The following is a description of a gene set: from publication Chen Y, Wang X (PMID 31504780) studied in species Mus musculus Genes predicted to be targets of miRBase v22 microRNA mmu_miR_6540_3p in miRDB v6.0 with MirTarget v4 prediction scores > 80 (high confidence targets). Mouse Gene Set: MIR_6540_3P, and this is the list of marker genes: Appl2, Sema4a, Rab8b, Smarcd1, Slc36a1, Igsf9b, Rnf38, Tex14, Gpr39, Cyth1, Ddc, Tlk2, Adk, Pcnx3, Kcnj11, Etfbkmt, Ptpn11, Klhl4, Pik3r3, Appl1, Gabra2, Naa16, Senp7, Hnrnpr, Gm6377, Usp34 (ubiquitin specific peptidase 34), Ddi2, Clgn, Arhgap21, Obox3, Foxo1, Upf2, Zfp24, Atad2b, Plagl2, Nptn (NCBI Gene Id 20320), Brox, Sdc4, Lmtk2, Efr3a, Alx4, Fmo5, Fcrl1, Mier2, Api5, Prpf8 (NCBI Gene Id 52899), Myh10, Adam22, Hnrnpd, Topbp1, Rbm27, Cct6a, Agpat3, Col19a1 (NCBI Gene Id 12823), Grem1, Pacc1, Kansl1, Usp40, Mybl1, Zfp316, Ankle1, Kcnd2, Abi3bp, Prrc2b, Camsap2, Ark2n, Eif4g3, Ppp6r2, Setd2, Crppa, Ltbp2, Atat1, Kcna2, Tm2d3, Dpt, Timm22, Lpp, Sema5a (NCBI Gene Id 320921), Prox1, Kcnt2, Ttll5, Zfp711, Tbc1d5, Npas3, Pxmp2, Ric3, Gas1, Sdcbp, Wtap, Castor1 (cytosolic arginine sensor for mTORC1 subunit 1), Polr2d, Trem2, Hmgb2, Fn1, Gpcpd1, Prelp, Nipa2 (NCBI Gene Id 93894), Elapor2, Tceanc2, Ank3 (ankyrin 3, epithelial), Sv2c, AI597479, Zfp467, Rgs19, Snrnp40, Rnf169, Nr2e1, Srpk2 (NCBI Gene Id 22382), Dbn1, Fam234b, Trim2, Asb15, Galnt11, Lsm6, Thap11, Hspd1, Dab1, Tpst2, Slc1a3, Azin2, Syt7, Gfer, Acat2, Prickle2, Diras2, Slc35d3, Rpl7l1, Fbrs, Strap, Aak1 (AP2 associated kinase 1)